Given this list of marker genes Sirt2, Art2b, Art1, Parp4, Potefam3b, Parp2, Art4, Sirt4 (sirtuin 4), Parp10, Parp1, Parp11, Tnks, Art3, Parp14, Potefam3a, Art5, Art2a, Parp8, Parp16 (poly (ADP-ribose) polymerase family, member 16), Parp6, Zc3hav1, Parp9, Tiparp, Ankrd66, Tnks2, Parp3, Parp12 (poly (ADP-ribose) polymerase family, member 12), here is a description of the gene set: species: Mus musculus Catalysis of the reaction: NAD+ + (ADP-D-ribosyl)(n)-acceptor = nicotinamide + (ADP-D-ribosyl)(n+1)-acceptor. Mouse Gene Set: GOMF_NADPLUS_POLY_ADP_RIBOSYLTRANSFERASE_ACTIVITY